Given this list of marker genes Spink6, Ecm1, Serpinb6b, Epha4, Tmed10, Serpinb6c, Serpinb9f, Eppin, Aph1c, Cldn3, Cstdc4, Gapdh, Grn, Spock3, Cstdc6, Ddrgk1, Csta3, Efna3, Vcp, Vtn, Serpinb9g, Psma3, Ager, Stfa3, Ubxn1 (UBX domain protein 1), Serpinb6a, Aph1b, Cst3, Timp3, Sfrp2, Timp2, Cst7, Serpinb9b, Psenen, Rcn3, Mbp, Timp1, Serpinb9c, Cldn13, Stfa2l1, Cstdc3, Serpinb1c, Psmb8, Nrdc, Ncstn, Wfdc6a, Stat3, Cstb, Spink5, Gapdh-ps15, Serpinb9h, Serpinb1a, Serpinb9d, Gapdhrt2, Prss22, Serpinb6e, Rhbdf2, Stfa2 (NCBI Gene Id 20862), Svbp, Serpinb9, Serpinb1b, Atp13a2, Spink1, Cldn4, Cast (NCBI Gene Id 12380), Serpine2, Fetub, Ctsh, Cav1, Reck, Antxr1, Gapdhrt, Spink2, Akt1, Vsir, Serpinb13, Crb2, Lyn, Csta1, Aph1a, Serpinb9e, Serpinb6d, Tank, Stfa1, Serpine1, Park7, Spock1, Bin1 (NCBI Gene Id 30948), Prelid1, Furin, Efna1, Cstdc5, Csta2, Serpinb8, here is a description of the gene set: species: Mus musculus Mouse Gene Set: GOBP_REGULATION_OF_PEPTIDASE_ACTIVITY Any process that modulates the frequency, rate or extent of peptidase activity, the hydrolysis of peptide bonds within proteins.